Given this list of marker genes Enpp7, Cyp8b1, Cldn15, Ugcg, Apoa4, Ldlr, Lep, Fabp2, Abcg8, Pnlip, Apoa2, Prap1, Npc1l1 (NPC1 like intracellular cholesterol transporter 1), Cldn2, Dgat1, Lpcat3, Scarb1, Cel, Apoa1, Abcg5, Npc1, Cd36, Acat2, Lima1, here is a description of the gene set: species: Mus musculus A process in which lipids are taken up from the contents of the intestine. Mouse Gene Set: GOBP_INTESTINAL_LIPID_ABSORPTION